Given this list of marker genes ITPR3, HLA-DQB1, ASPH, VCAM1, IL1R2, CD80, BCL3 (BCL3 transcription coactivator), HLA-C, GPAT3, HS3ST3B1, IL1R1, IL23A, WDFY4, AP1S2, CCN2, SLC27A2, SLC40A1, STAT4, CD4, here is a description of the gene set: Human Gene Set: LI_PBMC_MENACTRA_AGE_18_45YO_CORRELATED_WITH_ANTI_POLYSACCHARIDE_ANTIBODY_3DY_NEGATIVE species: Homo sapiens Many vaccines induce protective immunity via antibodies. Systems biology approaches have been used to determine signatures that can be used to predict vaccine-induced immunity in humans, but whether there is a 'universal signature' that can be used to predict antibody responses to any vaccine is unknown. Here we did systems analyses of immune responses to the polysaccharide and conjugate vaccines against meningococcus in healthy adults, in the broader context of published studies of vaccines against yellow fever virus and influenza virus. To achieve this, we did a large-scale network integration of publicly available human blood transcriptomes and systems-scale databases in specific biological contexts and deduced a set of transcription modules in blood. Those modules revealed distinct transcriptional signatures of antibody responses to different classes of vaccines, which provided key insights into primary viral, protein recall and anti-polysaccharide responses. Our results elucidate the early transcriptional programs that orchestrate vaccine immunity in humans and demonstrate the power of integrative network modeling. from publication Li S, Rouphael N, Duraisingham S, Romero-Steiner S, Presnell S, Davis C, Schmidt DS, Johnson SE, Milton A, Rajam G, Kasturi S, Carlone GM, Quinn C, Chaussabel D, Palucka AK, Mulligan MJ, Ahmed R, Stephens DS, Nakaya HI, Pulendran B (PMID 24336226) Genes negatively correlated with antibody response in peripheral blood mononuclear cell in adults (18-45) (anti-polysaccharide antibody-correlation profile) after exposure to Menactra, time point 3D